The following is a description of a gene set: studied in species Homo sapiens Reactome Pathway: B-WICH complex positively regulates rRNA expression The B-WICH complex is a large 3 Mdalton complex containing SMARCA5 (SNF2H), BAZ1B (WSTF), ERCC6 (CSB), MYO1C (Nuclear myosin 1c), SF3B1, DEK, MYBBP1A, and DDX21. B-WICH is found at active rRNA genes as well as at 5S rRNA and 7SL RNA genes. B-WICH appears to remodel chromatin and recruit histone acetyltransferases that modify histones to transcriptionally active states. part of: Positive epigenetic regulation of rRNA expression, and this is the list of marker genes: H4C1, TAF1A, H2BC12, TAF1C, H2AC20, H2BC26, TBP, POLR1H, TAF1D, H2BC9, H2BC12L, POLR2K, H2AC4, H3C15, POLR1D, MYBBP1A, POLR1E, BAZ1B, H2BC4, H2BC13, DEK, KAT2A, ERCC6, SMARCA5, H2AC18, H2AX, H2BC5, POLR2H, KAT2B, H2BC15, POLR2E, POLR2F, POLR1B, H2BC3, H2BC11, POLR1G (RNA polymerase I subunit G), POLR1F, POLR1C, SF3B1, H2AC6, POLR2L, H2BC21, H2AZ2, DDX21, H2AC14, H3C1, TAF1B, H2BC1, H2AB1, H2BC14, MYO1C, H2BC17, H2AJ, EP300 (E1A binding protein p300), H3-3A, ACTB, POLR1A, GSK3B, H2AC7